Given this list of marker genes TRIM44, CEP63, GPS2, TTC36, PLAA, MIR138-1, PPIA, PARP10 (poly(ADP-ribose) polymerase family member 10), here is a description of the gene set: Any process that stops, prevents or reduces the frequency, rate or extent of protein polyubiquitination. studied in species Homo sapiens Human Gene Set: GOBP_NEGATIVE_REGULATION_OF_PROTEIN_POLYUBIQUITINATION